The following is a description of a gene set: Human Gene Set: GOBP_PROTEIN_LOCALIZATION_TO_SYNAPSE species: Homo sapiens Any process in which a protein is transported to, and/or maintained at the synapse, the junction between a nerve fiber of one neuron and another neuron or muscle fiber or glial cell., and this is the list of marker genes: NPHS1, OGT (O-linked N-acetylglucosamine (GlcNAc) transferase), LHFPL4, GHSR, VPS26B, DLG4, GRIPAP1, GRIP1, NLGN1 (neuroligin 1), MAP2K1 (NCBI Gene Id 5604), RAB27B, KIF2C, GABARAP, ERBB2, PCLO, NRXN1, NETO1, CNIH3, CACNG3, CLSTN3, C1QL2, VWC2, SLITRK3, ABHD17B, ADAM10, ASIC2, SCRIB, CPLX1, DVL1, RAP1A, LGI1, GPHN, STX3, IQSEC2, CDK5 (NCBI Gene Id 1020), ZDHHC12, VPS35, MPP4, NSG1, SACM1L, CACNG2, NETO2, CACNG7, WNT5A, NPTX1, KIF5A, STAU1, EPB41L3, RAPSN, RAB11A, ZDHHC2, GIT1, LRRTM1, GRIP2, GRIN2A, GRIN2C, C1QL3, MAPT, TRAF6, DLG1, HSPB1, CACNA2D2, DAG1, GPC6, GPSM2, STAU2, KIF5C, RELN, NRXN2, MAP1A, ZDHHC15, NLGN2, ARHGAP44, BSN, TMEM108, WNT7A, LRRC7, KIF5B, RAB8A, DLG2, DLG3, SHANK1, OLFM1, MAPK8IP3, GPC4, BAIAP2, CLSTN1, ERBB4, HRAS, VAMP4